The following is a description of a gene set: species: Mus musculus Any process that activates or increases the frequency, rate or extent of progression through the meiotic cell cycle. Mouse Gene Set: GOBP_POSITIVE_REGULATION_OF_MEIOTIC_CELL_CYCLE, and this is the list of marker genes: Ooep, Rbm46, Dmrt1, Insr, Ythdc2, Prdm9, Igf1r, Npm2, Npr2, Meiosin (meiosis initiator), Eif4g3, Meioc, Dazl, Msx2, Lfng, Plcb1, Gja1, Ube2b, Piwil2, Cdc25c, Rad51ap1, Stra8, Camk2b, Fbxo5, Sirt2 (sirtuin 2), Cdc25b, Mapk15, Msx1, Ovol1, Wnt4, Cdc25a, Wnt5a